Given this list of marker genes ESR1, BMPR1B, MRPS22, ERAL1, FGFR1, RBM8A (NCBI Gene Id 9939), KISS1, PIGG, KIF14, PPP2R1A, FIGLA, TXNDC15, FSHR, POLR3H, GLI3, GNRHR, SPRY4, LARS2, NDUFB11, CYP11A1, HNF1B, SOX9, NELFA, PROK2, NUP107, WNT7A, NIN, MINPP1, HS6ST1, FOXL2, DCAF17, TACR3, CYP17A1, DHH, CYB5A, HCCS, STRA6, NSMF (NMDA receptor synaptonuclear signaling and neuronal migration factor), PROKR2, WDR11, DHX37, FGF8, BMP15, KISS1R, GNRH1, CPLX1, MSH5, CHD7, ZSWIM7, TAC3, NHLH2, NR5A1, SPIDR, IRF6, GATA3 (NCBI Gene Id 84828), BNC1 (basonuclin zinc finger protein 1), POR, B3GLCT, C14orf39, LETM1, NSD2, DUSP6, WNT4, TP63, AR, ADH5, ARID1B, COX7B, SOHLH1 (spermatogenesis and oogenesis specific basic helix-loop-helix 1), TOE1, PSMC3IP, PPP2R3C, FANCL, FGFRL1, CYP11B1, MYRF, MSH4, CLPP, CTBP1, FGF17, SOX11, here is a description of the gene set: species: Homo sapiens Human Gene Set: HP_APLASIA_HYPOPLASIA_OF_THE_UTERUS Aplasia/hypoplasia of the uterus Absence or developmental hypoplasia of the uterus.